The following is a description of a gene set: C57Bl/6 wild-type and STAT6 KO mice were used to study PPARg and IL-4 signaling. Bone marrow of 3 mice per group was isolated and differentiated to macrophages with M-CSF (20 ng/ml). 20 ng/ml IL-4 was used to induce alternative macrophage activation and 1 uM Rosiglitazone (RSG) was used to activate PPARg. From each mouse 4 samples were generated: 1. M-CSF, 2. M-CSF+RSG, 3. IL-4 and 4. IL-4+RSG. All compounds were added throughout the whole differentiation process, and frech media was added every other day. Control cells were treated with vehicle (DMSO:ethanol). After 10 days, RNA was isolated and gene expression profiles were analyzed using Mouse Genome 430 2.0 microarrays from Affymetrix. studied in species Homo sapiens Human Gene Set: GSE25088_ROSIGLITAZONE_VS_IL4_AND_ROSIGLITAZONE_STIM_STAT6_KO_MACROPHAGE_DAY10_DN from publication Szanto A, Balint BL, Nagy ZS, Barta E, Dezso B, Pap A, Szeles L, Poliska S, Oros M, Evans RM, Barak Y, Schwabe J, Nagy L (PMID 21093321) Genes down-regulated in bone marrow-derived macrophages with STAT6 knockout treated with rosiglitazone: control versus IL4., and this is the list of marker genes: IFIT3, PARP12, SEC61G (SEC61 translocon subunit gamma), CD63, DDX18, CLEC4E, FBXO4, COX20, TAP2, RALA, PDE12, DPH3, MGAT1, DARS1, SERPING1, SND1, TXNRD1, POMP, RILPL2, RPS28, MOB3B, MCEMP1, FLCN, ATP6V1D, HPS5, KYNU, GTF3C6, ATP13A3, CD53, SNX8 (NCBI Gene Id 29886), EML2, EBNA1BP2, ETS2, BCL2A1, P4HA1, UQCC4, TFG, GSTO1, ABCC1, SP140, GABARAPL2, RELA, MCTP1 (NCBI Gene Id 79772), MGLL, CD209, PSMC5, DERL1, MROCKI, LSG1, GRINA, PI4K2B, RIOX1, SPHK1, RBM28, SLC22A18AS, XBP1, GZMB, POLR2D, IFI6, DTX3L, DDX60, HACD3, SCARF1, NOP58, PSMA3, MB21D2, KLRB1, MRNIP, PIK3AP1, NR4A3 (NCBI Gene Id 8013), FCGR1BP, CD1E, GNS, PSMA1, MAT2A, TAP1 (transporter 1, ATP binding cassette subfamily B member), UBFD1, PITPNA, VEGFA, UBA2, NDUFAF8, SECTM1, PRKX, VAMP8, ANXA2P2, STAT4 (signal transducer and activator of transcription 4), UBE2Z, GNL3, HSPA5, SERP1, RBIS, ILRUN, CXCL1, ZNF146, RAB1A, IER3, WTAP, BOLA2, GCLM, SRSF10, NFKBIA, SMPD1, EAF1, ABCF1, AK4, CALU, DNAJB11, IL1A, DDX39A, TXN, MOV10, SLFN11, LIMS1, RCC2, SLPI, LONRF1, PRF1, SPP1 (secreted phosphoprotein 1), LRRC32, HPN, OSTC, SUPT5H, PSMB4, PDHA1, C1QB, TOLLIP, CALR, PDIA4, FLVCR2, MRPS7, HLA-DOB, CH25H (NCBI Gene Id 9023), NRIP3, ZNF593, SQOR, NCOA5, PARP14, GADD45B, RRAGC, RRN3, CXCL16, C3, CYSTM1, PSMB6, FNIP2, CCDC93, TBK1, SLC2A13, MRPL14, HSP90AA1, MAP2K1, FKBP2, TOMM40L, RPN2, MCM2, B3GNT5, APOL2, ADAM17, LAMB3, KARS1, HSPE1, ZEB2, SOD2 (NCBI Gene Id 79099), NOL10, PLPP3, IRF1, DIAPH2, ARHGAP31, FBP1, GNL2, TWSG1, FPR3, TEX261 (testis expressed 261), SMPD2, EIF4A1, AZIN1, C5orf15, IL1RN, GIMAP2, RBM17, RAB13, ALDH1A2, PLAUR, CFB, TRMT112, TGM2, STOM, RRN3P3, PROCR, TUFM, EBI3 (NCBI Gene Id 10148), MTF1, PHACTR2, UBQLN1, SEPHS2, PSMB9, RFX5, YWHAG